The following is a description of a gene set: Human Gene Set: GOBP_INFLAMMATORY_RESPONSE_TO_WOUNDING The immediate defensive reaction by vertebrate tissue to injury caused by chemical or physical agents. species: Homo sapiens, and this is the list of marker genes: DSG2, F2R, IL33, NFKBIZ, MIR21 (NCBI Gene Id 406991), SIGLEC10, TLR4, PTPN6, MIR17, STAT3, PPARG, TGFB1, MAPK9, ALOX5, GIT1, CCR2, TNF, IL6, AGER, MDK, REG3A, IL1A, GRN, WDR83, HIF1A, TLR3, IL17A, TIMP1, HMOX1, EXTL3